Given this list of marker genes MBD3 (methyl-CpG binding domain protein 3), LARS2, MBD4, CD48, ZNF813, RACGAP1, MRPL13, PMCHL1 (NCBI Gene Id 5369, pro-melanin concentrating hormone like 1 (pseudogene)), SRSF3, ZC2HC1A, TBX10, GALNT7, MPRIP, MAN1A1, EGLN1 (NCBI Gene Id 54703), NUP37, BNC2, ACKR4, CHAF1B, HADHA, DRICH1, BSDC1, NUDT15, TCERG1, ZNF287, AMT, CD40, ARHGAP6, EDAR, RPS24 (NCBI Gene Id 6229), SLC25A11, MPST (NCBI Gene Id 4357), CEACAM6, RP2, KIF22, BTG3, MPV17, SLAMF7, FAM193A, DIXDC1, BMERB1, RNF44, IGF1R, ARHGEF11, COLGALT1, RIPK2, ACAD8, SETD3, MIA2, GLB1, RTL8C, ATG14, XCL1, SPOP (NCBI Gene Id 8405), INSIG1, MCM3, NUCKS1, HTR3B, ZNF675, KIF3C (kinesin family member 3C), RLIG1 (NCBI Gene Id 91298), DOK2, CELA3B, UTS2, CD68 (NCBI Gene Id 968), MRPL40, TPTE, EXT2, RBM6, PLPP3, ATP2B1, EIF5, NFE2, LHX3, MAFF, RBM22, TTC3, CIR1, WTAP, VPS39, CUL4A, DCXR, HNRNPM (NCBI Gene Id 4670), HLA-DMA, BRD9, TMEM9B, TMX1, WFDC2, IFNA2, PLD1, LILRA1, HIKESHI, RTF1, FASTKD5, ZDHHC3, CD99, NTN3, CYB5B, EBI3, LZTR1, EIF5A, GMFG, SLC25A3 (NCBI Gene Id 5250), H1-1, DDX46, DPAGT1, VIPAS39, DEGS1, TPP1, EIF2B2, ARHGAP11A, LIMD2, THAP3, KPNA2, TRIM25, MED12, CDC25B, THRA (NCBI Gene Id 7067), SPHK1, FAM32A, AK4, DUSP10, CRYZ, CAPG, PNMA8A, UTP20, GCA, SLC9A6, FXYD6, SEC11A, PNKP, MKNK1 (NCBI Gene Id 8569), SAMM50, AIMP1, CLDN1, DCTN3, CSK, PREX2, HMGB1, SLC35C2, ZNF282 (zinc finger protein 282), SNRNP40, FAM114A1, CLCC1, TDRKH, MARCHF5 (membrane associated ring-CH-type finger 5), LCMT1, KDM3B, NR1H4, RPS17P5, SLC6A8, OSBPL3, ZNF185, ITPR1, AGT, IGLV1-44, RAB17, IL36G, TMEM267, C1GALT1C1, ANKRD27, COPS7A, KMT5B, B3GNT2, MT3, RNF38, BMS1 (NCBI Gene Id 9790), TMEM147, NOX5, TRPV1, ABHD17A, ACTG1, ATP13A3, RFWD3, HECTD4, FUT5, CENPE, TST, SUPT3H, APBB2, GTF2E1, ENPP3, USP13, GDAP2, PHACTR1, IMPA1, GNPDA1, TEAD1, CDK5RAP1, ABCB1, SYNE2, ARFGEF1, OTUB1, SAE1, TRMT12 (tRNA methyltransferase 12 homolog), CNPY3, NIT2, here is a description of the gene set: Genes up-regulated in HEK293 cells: over-expressing wildtype NOD2 versus control. from publication Billmann-Born S, Till A, Arlt A, Lipinski S, Sina C, Latiano A, Annese V, Häsler R, Kerick M, Manke T, Seegert D, Hanidu A, Schäfer H, van Heel D, Li J, Schreiber S, Rosenstiel P (PMID 21335489) NOD2 is an intracellular receptor for the bacterial cell wall component muramyl dipeptide (MDP) and variants of NOD2 are associated with chronic inflammatory diseases of barrier organs e.g. Crohn disease, asthma and atopic eczema. It is known that activation of NOD2 induces a variety of inflammatory and antibacterial factors. The exact transcriptomal signatures that define the cellular programs downstream of NOD2 activation and the influence of the Crohn-associated variant L1007fsinsC are yet to be defined. To describe the MDP-induced activation program, we analyzed the transcriptomal reactions of isogenic HEK293 cells expressing NOD2wt or NOD2L1007fsinsC to stimulation with MDP. Importantly, a clear loss-of-function could be observed in the cells carrying the Crohn-associated variant L1007fsinsC, while the NOD2wt cells showed differential regulation of growth factors, chemokines and several antagonists of NF-κB, e.g. TNFAIP3 (A20) and IER3. Human Gene Set: GSE22611_NOD2_VS_CTRL_TRANSDUCED_HEK293T_CELL_UP studied in species Homo sapiens